The following is a description of a gene set: Human Gene Set: LXR_DR4_Q3 Genes having at least one occurrence of the motif TGACCGNNAGTRACCC in the regions spanning 4 kb centered on their transcription starting sites. This matches the NR1H3 transcription factor binding site V$LXR_DR4_Q3 (v7.4 TRANSFAC). studied in species Homo sapiens, and this is the list of marker genes: FKBP2, ADAMTS4, HPCAL4, ACACA, IKZF2, SLC2A4, KDM2A, JARID2, TAF11, NUAK1, BCL3, OTX1, PRKCG, NR2E1, PTK7, YWHAZ, SYT17, NR5A1, DRD1, PEX11B (NCBI Gene Id 8799), BRWD3, RTL9, GNB2, LPCAT3 (lysophosphatidylcholine acyltransferase 3), MSANTD2, SULF1, NACC1 (NCBI Gene Id 112939), CIC, AZI2 (NCBI Gene Id 64343), APOC1, BZW1, FOXP1 (NCBI Gene Id 87246), PUM2, HEPACAM, RB1CC1, RNF145, SGK1, SKA2, STAC2 (NCBI Gene Id 342667), STAG2, CTCF, ABCG1, SPTBN4, TP53INP2, PRDM12, SYT3, RINT1, POLA1, LIN28A (NCBI Gene Id 79727), ACSL3, CHCHD1, KDM6A, CCDC9B, MEF2C, OAZ2, FRMD5, PPARD, SALL2, NELL2, PRR11, JADE2, ZFHX3, HDAC4, COL16A1, DTX3, FOXP2, HIC1, FOXD3, NDUFS2, TTC9C, COL11A2, BLVRB, ABCA1, ACTA1, PIAS1, RBFOX1, PPP4R3B, GJD2 (gap junction protein delta 2), ETV4, ETV6, RARA, NALF2 (NALCN channel auxiliary factor 2), PLAG1, MRI1, MAFB, TFEB, GNRHR2, NR5A2, MID1IP1, CHMP2B, LRP3, SPOP, MITF, PODXL2